Given this list of marker genes THPO, NHERF1, GC, CFH, ITGB3, KITLG, CPS1, SEBOX, YTHDF1, CFHR2, ANG, LAMP2, DHCR24, CDC16, CTSV, SNX10, ADAM9, MB, PTPN2, RNASE4, KLC4, ETS1 (NCBI Gene Id 2113), KCTD10, IL13RA1, PKDCC, MAG, BCL2L2, AMBP, MAP4K3, XDH, ZFP36L1, MPEG1, SLC39A1 (solute carrier family 39 member 1), NID1 (NCBI Gene Id 4811), B2M (beta-2-microglobulin), C3, FBN1, NNMT, GRK2, ABCF3, TIPARP, RPL37, HTATSF1, SEMA6B, MAP7D1, HSP90B1, HNRNPD, CLIP3, EXOC8, COX6C (NCBI Gene Id 1345), SH3YL1, COL14A1, INPP5A, PHF5A (PHD finger protein 5A), SERINC1, ANXA2, RBM10, LAMB2, TFF3, UBL3, HAT1, ATP5PB, PDCD4, CD34, LRRC8A, APOA5, ERLIN1, WARS1, NUCKS1, TAF1C, RBP2, MARCHF5, GAS6, GNG12 (G protein subunit gamma 12), CYP3A7, ETAA1, LCN2 (lipocalin 2), ABCE1, KIF22, TSPAN4, LBR, GART, UNC45A, DCAF12, SAA1, MED28, PLA2G7, RRP7A, OSMR, FCRLA, HBB, HOXA11, A2M, ORM1, ELOVL2, GPC3, VPS26B, GADD45G, IVNS1ABP, SLC3A1, ASRGL1, PROS1, B4GALNT1, HIP1R (NCBI Gene Id 9026), ABCA1, SRSF2, PTDSS2, C5 (NCBI Gene Id 727), SYNE4, HBA2, COL1A1, DYNLT3, PLPPR2, NFIA, RNF44, SAT1, NCOA4, PRKAR1A, PLD1, CRABP2, PIGF, KIAA0319L, FGG, ADAM23, ITGB2, MAPK14, ATP13A1, CCDC80, ATP11A, DHX40, DDX5, SOWAHC, KDELR2, HRG, RRBP1, PHC2, SPTBN1, MMS19, SPTLC2, AGO2, CPNE3, H3C14, ITIH4, KCNJ12, ACTR2 (NCBI Gene Id 10097), NRDC, PBX2, UBE2D3, SNTB2 (NCBI Gene Id 6645), ITIH3, ADGRA3, CD14, RPL10, SH3BP2, TOLLIP (toll interacting protein), ENPEP, DSC1, AHR, RO60, CYTH1 (NCBI Gene Id 9267), C6orf62, BDKRB2, FOXN2, PMS2, KCNJ8, FABP4, WSB1, HPD, ADCK1, CFI, IFRD1, PPP1CB, TBC1D14, LGALSL, JCHAIN, DNAJC21, ZZZ3, RPAP3, ESYT1, SLC25A15, FKBP5, FLI1, SLTM, COL6A1, ANAPC4, SUPV3L1, ITPR1, NEK4, TRPM7, CCDC86, SLC44A1 (NCBI Gene Id 63942), CDC20, ADGRE1, PACS1, RIPK1, SERPING1, FGB, ITIH1, BRD8, COL6A2, here is a description of the gene set: Expression profiling of Rag2-deficient Ets1++ and Rag2-deficient Ets1-- mature NK cells and WT bone marrow progenitors, WT T cells, and WT Pro B cells studied in species Homo sapiens Genes up-regulated in NK cells: RAG2 knockout versus RAG2 and ETS1 knockout. from publication Ramirez K, Chandler KJ, Spaulding C, Zandi S, Sigvardsson M, Graves BJ, Kee BL (PMID 22608498) Human Gene Set: GSE37301_RAG2_KO_VS_RAG2_AND_ETS1_KO_NK_CELL_UP